Given this list of marker genes KDM1A, EHMT1 (euchromatic histone lysine methyltransferase 1), KDM5B, GRIA1, KDM6B (lysine demethylase 6B), SRD5A1, here is a description of the gene set: Human Gene Set: GOBP_RESPONSE_TO_FUNGICIDE Any process that results in a change in state or activity of a cell or an organism (in terms of movement, secretion, enzyme production, gene expression, etc.) as a result of a fungicide stimulus. Fungicides are chemicals used to kill fungi. species: Homo sapiens